The following is a description of a gene set: Type II diabetes mellitus A type of diabetes mellitus initially characterized by insulin resistance and hyperinsulinemia and subsequently by glucose interolerance and hyperglycemia. Human Gene Set: HP_TYPE_II_DIABETES_MELLITUS studied in species Homo sapiens, and this is the list of marker genes: BLM, MT-TH, TCF7L2, DYRK1B, POLR3A, SIN3A, GLRX5, FBN1, VPS37D, GTF2I, MT-TF, CAT, IRS1, KLF11, ATM (NCBI Gene Id 8068), LZTFL1, BAZ1B, PPP1R3A, SCAPER, CNBP, AMACR, SLC2A2, GTF2IRD1, PCNT, IFT27, MAPK8IP1, TRIM32, PCYT1A, IRS2, MKKS, IL6 (interleukin 6), PPARG, MT-ND4, BBS10, BBS5, HNF1A, LIG4, AIP, BBIP1, MKS1, MAFA, CLCNKB, POLA1, NPAP1, MKRN3, BSCL2, CFAP418 (NCBI Gene Id 157657), IFT74, TMEM270, WFS1, WDPCP, HERC2, CEP290, DNAJC30, CELA2A, SNORD115-1, INSR, CYP19A1, NEUROD1, GTF2IRD2, XRCC4, METTL27, MTNR1B, GPR101, SIM1, IGF2BP2, SCLT1 (NCBI Gene Id 132320), BBS9 (NCBI Gene Id 27241), STUB1, AKT2, ABCC8, RFC2, PNPLA6, PEX10, BBS12, BRAF, RETN, MT-CO2, FKBP6, BUD23, MT-TW, IFT172, HMGA1, ENPP1, MT-ND6, CEP19, LRP6, BBS4, SLC30A8, GPD2, BBS2, MOG, NPHP1, MAGEL2, MT-TL1, BMP6, EIF4H, MEN1, CPE, THRB, PWRN1, CTNNB1, DMXL2, LMNA, MANF, CTRC (NCBI Gene Id 11330), CLIP2, HNF4A, PLCD1, MT-TS2, SPINK1, BBS7, SNORD116-1, DNMT1 (DNA methyltransferase 1), HNF1B (NCBI Gene Id 6928), MT-TQ, LMF1, MC4R, GCGR, ALMS1, AR, CARS1, LIMK1, SDCCAG8, MT-CO3, GCK, PTPN1, MT-ND5, PDX1, TBL2, MT-ND1, TTC8, MPV17, WRN, LIPC, ELN, SLC12A3, PWAR1, NCF1, PAX4, MT-CO1, BBS1, STX1A, ARL6